Given this list of marker genes Entpd3, Nt5dc2, Nt5c3b, Nt5c1b, Nt5c, Nt5m, Bpnt1, Bpnt2, Acp3, Nt5e, Nt5c3, Nt5dc1, Nt5c2, Nt5c1a, Enpp7, Nt5dc3, here is a description of the gene set: Catalysis of the reaction: a nucleotide + H2O = a nucleoside + phosphate. Mouse Gene Set: GOMF_NUCLEOTIDASE_ACTIVITY studied in species Mus musculus